The following is a description of a gene set: species: Mus musculus Mouse Gene Set: REACTOME_INTERLEUKIN_3_INTERLEUKIN_5_AND_GM_CSF_SIGNALING Interleukin-3, Interleukin-5 and GM-CSF signaling, and this is the list of marker genes: Yes1, Il2ra, Cbl, Pik3r1, Uba52, Prkaca, Crk, Ptpn11, Ubc, Uba52rt, Jak2, Vav1, Inpp5d, Csf2, Ywhaz, Il3, Lyn, Pik3r2, Inppl1, Il5ra, Hck, Il2, Il2rg, Stat5a, Sos1, Pik3cd, Pik3r3, Csf2rb, Csf2rb2, Grb2, Rps27a, Il5, Crkl (v-crk avian sarcoma virus CT10 oncogene homolog-like), Il2rb, Shc1, Ptpn6, Fyn, Ubb, Pik3cb, Stat5b, Pik3ca, Rapgef1, Syk